The following is a description of a gene set: from publication Howe DG, Blake JA, Bradford YM, Bult CJ, Calvi BR, Engel SR, Kadin JA, Kaufman TC, Kishore R, Laulederkind SJF, Lewis SE, Moxon SAT, Richardson JE, Smith C (PMID 30224793) Mouse Gene Set: HALLMARK_INFLAMMATORY_RESPONSE species: Mus musculus Mouse genes annotated to HALLMARK_INFLAMMATORY_RESPONSE based on orthology mappings provided by the Alliance Genome Consortium, and this is the list of marker genes: Nfkb1, Acvr1b, Il12b, Cd14, Adm, Ifngr2, Kcnmb2, Cmklr1, Fzd5, Slc11a2, Kcnj2, Cxcl9, Cxcl5, Lta, Slc28a2, Tlr2, Gch1, Cxcl15, Scarf1, Sema4d, Gabbr1, Il15, Rnf144b, Tacr1, Nlrp3, Ifitm1, Rgs1, Nampt, Abi1, Irak2, Mep1a, Sele, Axl, Tpbg, Ripk2, Gpr132, Gpc3, Il10, Msr1, Psen1, Cd40, Met, Cd82, Nmi, Marco, Tlr3 (NCBI Gene Id 142980), P2ry2, Il2rb, Cd70, Adrm1 (NCBI Gene Id 99832), Ccl5, Aplnr, Itgb8, Sgms2, Il6, Chst2, Prok2, Bst2, Slc7a2, Il18r1, Tnfrsf9, Bdkrb1, Cybb, Itga5, Gp1ba, Klf6, Lck, Serpine1, Tnfsf10, Scn1b, Adora2b (NCBI Gene Id 632506), Csf3r, Ccl17, Sell, Best1 (NCBI Gene Id 24115), Hif1a, Cxcl10, Tlr1, P2rx4, Stab1, Ldlr, Tnfsf15, Emp3, C3ar1, Slc4a4, Fpr1, Hrh1, Ereg, Mmp14, Gna15, Lpar1, Ccr7, Il15ra, Osm, Dcbld2, Aqp9, Rtp4, Atp2a2, Tnfrsf1b, Btg2, Clec5a (NCBI Gene Id 58174), Slamf1, Eif2ak2, Myc, Edn1, Tnfaip6, Pcdh7, Slc31a1, Csf3, Lamp3, Il1a, Ptger4, Lyn, Rhog, Rgs16, Inhba, Cxcr6, Il1b, Vip, Ros1, Tacr3, Cd69, Ccl7, Pik3r5, Icam4, Ly6e, Lcp2 (NCBI Gene Id 16822), Il4ra, Gpr183, Ptger2, Has2, Slc31a2, Il7r, Timp1, Abca1, Icosl, Slc7a1, Ifnar1, Mefv, Nod2, Cd48, Cxcl11, Ffar2, Gnai3, P2rx7, Tapbp, Adgre1, Ptafr, Atp2b1, Pdpn, Cx3cl1, Il10ra, Cdkn1a, Csf1, Ccrl2, Pvr, Rela, F3, Npffr2, Ccl20, Ebi3, Rasgrp1, Il18, Il18rap (interleukin 18 receptor accessory protein), Plaur, Ccl22, Atp2c1, Icam1, Ahr, Tnfsf9, Ccl24, Pde4b, Il1r1 (NCBI Gene Id 16177), Irf1, Osmr, Ndp, Itgb3, Kcna3, Selenos, Nfkbia, Calcrl, Sri, Hpn, Ptpre, Acvr2a, Oprk1, Ptgir, Hbegf, Irf7, Slc1a2, Sphk1, Mxd1, Olr1, Lif, Raf1, Kif1b, Nmur1